Given this list of marker genes TTI2, PAFAH2, RGS20, F11-AS1 (F11 antisense RNA 1), ITSN1, MSANTD2, MED12L, MRPL3, PCLAF, IPCEF1, EFNA5, SRF, STRIP1, EFCAB6-DT, TXN2, CCNC, UNK, YAP1, KIFAP3, ABI2, UBE2V1P14, ZNF575, SNORD27, RPL21P40, VPS28, SCFD1, C11orf98, ALKBH2, CYB5B, CPEB2, RPS26, LINC02716, DAGLB, KANSL3, UTS2, RNU4-9P, RN7SKP95, N4BP2L2, LINC00705, TLN1, FAM133B, SRCAP, B2M, SCAF1, HUS1, UBE2Z, LINC02739, SFSWAP, CCDC107, COX7A2L, ATG101, PPIG (NCBI Gene Id 9360), ELMO1, GIN1, GPSM3, CASP7, KDM1A, DRG2, LRRC14, ARHGEF1, HSPE1-MOB4, XRN1 (NCBI Gene Id 54464), ENSG00000255357, GSPT1, FBXO4, MFSD4A, FBXW5, KIAA0319, ATXN2L, H4C3, SNAP47, HNRNPA1, MRPL30, TTC21B, CYYR1, TMEM242-DT, TUBB, TAFA2 (TAFA chemokine like family member 2), SLAMF1, RAD1, NOB1, ENSG00000252188, FBXO34, SEC62, METTL18, EMG1, C9orf43, RNU6ATAC32P, SYMPK, PVT1, NWD1, NELL2, EIF3H, METTL13, MT-TW, SLC3A2, CTSA, DROSHA, ENSG00000253214, MAP3K7, FOXRED1, BRD4, UBB, TOP3B, SMG8, PDCD6, CTSC, SMIM8, EVI2B, TAS1R1, TBC1D17, INO80C, GUSBP1, PFDN4, ERVK3-1, FUT11, RPS7, GABARAP, RPL10A, MDP1, PRMT5, VAMP1, TPRG1, RPL22, GBA1LP (glucosylceramidase beta 1 like, pseudogene), PRCP, PNPLA8, TMEM108-AS1, WDR70, LINC02794, SNORD15A, MCL1, FBXW2, TIMM44, NR1H3, IMPDH2, NKAPD1 (NKAP domain containing 1), LINC01775, NEU4, CNN3, BTG1-DT, ERRFI1, TXNRD2, TLE6, RTRAFP1, BANP, MIR4503, HCG20, LYSMD1, RPS13P5 (NCBI Gene Id 100271061), ACAD8, DDX5, SMAD6, CDC40, TIA1, TAF13, DYNC2I2, USP22, DNAJB4, RPL24, SNORA57, PACERR, ALOXE3, AMBN, SLC25A5P7, ANG, RCC1, BSCL2, TMPO-AS1, LINC02609, SLC25A25, CLCC1, KDSR, C12orf57, SCAI, SNORD26, TMEM241, PIH1D2, ARIH1, HIGD2AP2, TBL1X, TFG, RRAS, PDCD6-DT, ZNF770, RBBP5, ATXN7L1, EIF4E2, SCG2, PAK1, CYP4F22, SNORA8 (NCBI Gene Id 654320), ULK3, FRS3 (NCBI Gene Id 10817), DBF4B, SPARC, FBXO34-AS1, FADS2, DNAJC9-AS1, ATP6AP1L (NCBI Gene Id 92270), FUS, NUFIP2, EIF3F, PLEKHA3, ERCC1, COA5, NUDT17 (nudix hydrolase 17), THOC5, UBQLN1, SLC25A21, RNY4, TACO1, MRPL34, HDHD2, PRR7, EXOSC3, METTL1, LY6K, ELP3, H2BC8, SYCE2, CCDC97, VPS50, C8orf82, RINT1, IL4I1, TUBA1B-AS1, STEAP1, SREBF2, DDX19A, COA6, NUAK1, TRNAU1AP, KCNIP2-AS1, MRPS23, COL6A5, NLRC5 (NLR family CARD domain containing 5), MSTO2P, CHD1, PDE4A, GSTA4, DHRS13, TMEM138, DMAP1, ALDH1A2, AURKAIP1, RPL10, TMEM183AP4, MIR4512, AFMID, SBDSP1, RBM39, REX1BD, MIR4645, TRAJ35, RUVBL1, JMJD4, GALK2, FBXO11, CYCSP26, LTBP4, PRPF18, RUBCNL, CECR3, TGIF1, ZBTB45, LAMA4, ZNHIT2, PPP1R1C, HSPE1, TM9SF3, MINCR, DUSP6, CNIH2, CREB3, ENSG00000255476, SEZ6, OTOGL, MEPCE, PABPN1, COX16, SEL1L3, RBMS3, PRR7-AS1, SFTA2, PDE8A, PARP2, RBM11, STAT1, ENSG00000181123, SEC13, LINC01089, SNRNP35, IMMT, RN7SKP175, TPH2, SSBP2, MAPK1IP1L, NFX1 (NCBI Gene Id 94733), PEBP1P1, LDLRAD4, TEDC2 (tubulin epsilon and delta complex 2), ENSG00000268129, RPS23, RPL26 (NCBI Gene Id 6154), TRIB1AL, EFCAB6, GNG12-AS1, ASPH, TMEM260, BBS4, RMDN3, UBFD1, SETD5, KIAA0586, WEE2-AS1, FEZ2, NCOA7, ZNF687, SNU13, MEIS1, SLC39A8, ALKBH5, RPS18, RGS12, H4C13, NOSIP, RETSAT, F5, LINC02847, NME1-NME2, EXOSC4, TMEM39A, TTLL3, KLHL22, GLUL, PRRT1, PTP4A2, SAV1, PTCH1, B3GALT9, TNFAIP6, RUNX2, PXMP2, PNPT1, NUDT4, REXO4, ELP5, HIGD2B, C11orf91, DIXDC1, RDH11, IL16 (interleukin 16), PDE7B-AS1, PTCD1, RNASE4, GBA1, NGRN, LRATD2, ARRDC3, TBC1D4, ZNF423, NRDC, SEH1L, PHB2, NAIF1, MT-RNR2, UQCRH, AGAP2-AS1, VOPP1, ADAM28, CSKMT, RMRP, RBM25, MEX3C, U2SURP, ANKRD28, RNU6-899P, FPR3, PSMA1, VPS51, RAD23A, ZNF34, PCDHA13, POLG2, ZNF76, SPCS2, CHAMP1 (NCBI Gene Id 84453), GFM1, XRRA1, PRDM10, LINC01363, THYN1, LINC02909, POLE3, FFAR3, LINC00690, UTP3, RBM28, RNA5SP436, LIMA1, FIBP, NACA, ACBD4, STK19 (serine/threonine kinase 19), TANC2, STT3A, SSBL4P, ZNF837, SAMD4A, PRRG2, CD82, HSPD1P1, PDIA5, TOMM6, SNX1 (sorting nexin 1), NFIC, UBXN1, XBP1 (NCBI Gene Id 7494), RNU7-27P, ZNF212, KIAA1586, VPS52, KIAA1217, CASC11, GEMIN6, NOC3L, TMEM222, FAM53C (family with sequence similarity 53 member C), PPP1R10, POLI, ZNF767P, ATAD3A, RPS4X, CEP120, SCGB2A1, LINC03017, EIF1AD, C22orf46P, LMLN, RNU1-19P, WDR35, EPHA4, PPIF, LINC01495, POLG-DT, RBM4 (RNA binding motif protein 4), SNORD5, RRP15, ACP2, ZFAT (zinc finger and AT-hook domain containing), HCG14, CALM1, RPL27A, BCAR3, P4HB, AP2M1, HHAT, SLC7A11 (solute carrier family 7 member 11), CDK5RAP2, NUP62, NPRL3 (NCBI Gene Id 8131), CASTOR1, CENPU, PPP1R37, LINC02309, ATP6V1D, SNORD25, PTGS2 (NCBI Gene Id 5743), NCAM1, LINC02098, COMMD9, MTF2, RNU6-2 (NCBI Gene Id 103625684), SNTG2, BAZ2A, THAP7-AS1, COPS7A, MFSD6, USP2, HNRNPF, ZNF318, C8G, LINC01569, SETD6, UBC, CTDNEP1, RAB11A, DDB2, UTRN (NCBI Gene Id 7402), CDC25C, SCNM1, COPS2, PLEKHG7, BDNF, NCK1, H1-10, GGACT, RNU6-1, CFDP1, MIR5087 (microRNA 5087), MIRLET7A1HG, NAT10, SELENOH, ZNF513, WBP1L, SUPT20H, RNU6-1055P, PPIB, LRRC41, ZNF131, CHD2, RPL7AP57, SNHG1, XRCC2, SNRNP27, ZNF668, INPPL1, JPX, SRPRA, APOH, ATG16L1, ETV6, HM13-AS1, DYNC1I2, MTIF3, SRSF5, METTL15, TRAJ3, LSG1, FERMT3, NRCAM (neuronal cell adhesion molecule), PRPF4, LINC01322, ZNF428, ZC3H10, MALAT1, ESYT1, LINC01812, VPS41, SPRYD4, H4C6, KDM3B, TOB2, TNRC6C, C2CD3 (NCBI Gene Id 26005), PAFAH1B1, PROSER2-AS1, TAP2, CTNND1, CWC27, DLGAP4, RPL7L1P13, SLC25A51, LINC02695, HTATSF1P2, RPL21P126, NAPA, LINC02846, POM121, DHPS, HTD2, MT-TV (mitochondrially encoded tRNA-Val (GUN)), PPP1R21, CDKAL1, ADPRHL1, QSER1, VPS4B, LAPTM4A, RNF121, HIPK1-AS1, TIMM9, NEURL2, EYS, NOL9, UNC50, DIAPH1, ACTB, VWA5A, MIR759, HMCN1, EXOSC6, POLQ, RNU7-90P, TMEM259, LINC01960, ARL14EP, MAPK8IP3, TTF2, OSTM1, BOLA1, TK1, SIRT6, KCNIP1 (potassium voltage-gated channel interacting protein 1), MTCO3P12, ANKRD40, ZNRD2, SSBP1, VARS2, EPB41L4A-AS1, TMEM258, HCG21, PWWP3A, MAGEF1, EEF1A1P25, PLEKHG2, ZNRD2-DT, DNM1L, FBXW9, SRSF7, BYSL, TUT1, CYTH1, KIF18A, ABCA5, KAT7, ATP5PO, IL34, ISY1-RAB43, CYB561A3 (NCBI Gene Id 378885), RPS24, H2AC21, UBA52, DIP2C, CASP9, LINC01719, MYBPC1, THAP1, MYOM2, TARS2, ABHD16A, USP2-AS1, TRD-AS1, ELMOD3, MED20, OGA, ITFG2, BMPER, SMG7, PPME1, HCG24, RNU12, PSMC4, SMIM27, PCBP1-AS1, ARID1A, LUZP1, HNRNPR, PRKAG1, XKR5, MICU1, LINC01132, MORC3, CD68, TAF3, TENM2, PIGC, SDC4P, ATP1B3, TRIP4, GPATCH2L, IRF2-DT, PPT2-EGFL8, GRAMD4P8, LINC00426, SFT2D3 (SFT2 domain containing 3), GEMIN8, MAP4K3-DT, CDK5RAP1, BMPR1A, ADAT1, TAF1D, CRK, LIMS1-AS1, STC1, SLC9A1, FBXO31, CNPY4, LBR, SNX19, MARVELD3, EIF2AK2 (NCBI Gene Id 5610), IQCG, GPX1, SNAPC5, LOXHD1, CYREN (cell cycle regulator of NHEJ), SH2B1 (SH2B adaptor protein 1), ENSG00000267764, INTS4, PEX2, ZC3H3, RHOH (ras homolog family member H), MED18 (mediator complex subunit 18), TIGD1, AKT1S1, SNORA13, TRMT12, C19orf53, SLC30A4-AS1, ZAR1L, KLHL20, SNORD3A, SNHG12, DLGAP1-AS2, POLR2M, SOX6, COL20A1, MAZ, NEB, ARHGAP26, TRAPPC3L, LINC01275, SMARCC2, HSPD1, NDUFAF4P1, BTG1, SYT16, C2orf42, CUL5, LINC02732, AP5S1, THBS3-AS1, TRIO, IFTAP, TRMO, MRPL38, BBOX1-AS1, RASAL2, ZKSCAN4, ENSG00000248161, EFCAB5, CCDC80, ANXA11, SLC35C2, ENSG00000200538, JPT1, NEK3, HABP2 (NCBI Gene Id 3026), DIAPH1-AS1, TPM1, PAF1, LRP3, CCAR2, MIR4799, TIMM10, GS1-24F4.2, IRF2 (NCBI Gene Id 3660), TINF2, RNU4-91P, MRPS18CP6, FDX1, DDX19A-DT, ATG16L2, METTL26, IRF9, WRAP53, WDR35-DT, PIK3CG, CEP95, CHD7, GORAB-AS1, CCNY, PSEN1, TMEM232, ATF5, RCN3, LINC01571, TMEM242, SLC33A1, SEMA3A, RBMS3-AS3, MDM4, SMARCD2, RBMS3-AS2, ZNF846, DNAI3, ANKRD13C-DT, FAM43A, FIRRM, JAKMIP2-AS1, NDUFV2, TRAPPC12, UBA1, CCDC102B, KRT127P, AKAP13, COL21A1, NME1, FOCAD, ZNF43, DNAJC16, NEMF, C11orf54, TMC1, MRPS15, CRABP1, MIR924HG, PTPA, RPS3, KCTD14, PPP6R1, BRIX1, NOL7, KNL1, CLIP1, ATP7A, PAXBP1, MITD1, ZNF778, ATF6, ZNF532, HCLS1, UTP25, MRPL19, EIF2S1, CLPB, TFAP2A, CLASP1, POLG, PPT2, ZEB2, RNU6ATAC, DNAJB14, ARHGAP21, MPP4, PLPP6, BPHL, ZCCHC4, BANF1, SLCO4A1-AS2, ROBO3, TBPL1, CCDC9, SHTN1, ITFG2-AS1, TUFM, ZW10, AAAS, HNRNPA2B1, GTF3C3, LINC02218 (NCBI Gene Id 102723526), TSG101, AOX1, GLI1, APRT, CARS1, AP1M1, MED6, CACYBP, MIATNB, ISY1, CDC42EP5, PSMD9, PRKRIP1, CNOT11, MIRLET7A1, EEF1AKMT3, DXO, WASF1, SMG7-AS1, THUMPD3-AS1, GSAP, GADD45B (NCBI Gene Id 4616), NR1H2, LRCH1, HIPK1, SMURF2P1, LINC02104, BDH2, GADL1 (NCBI Gene Id 339896), SMAD3, PREP, CLTC, TLN2, FZR1, SCAT8, AMOTL1, FAM98B, STK17A, MIRLET7F1, CPSF4, SAMD1, MIPEP, SRBD1, ZBTB11, CYP4V2, EPCIP-AS1, UNC80, RGL2, SNORA16A, SDHAF2, CRBN, CD101-AS1, RLIM, RAB2A, KLHDC2, MCRIP2, MCOLN1, ADRA1D, MIR5695, PLD1, NDUFC1, KIFC3, YTHDF2, ROCK1, HIKESHI, DPP9, CDC42SE2, MYEOV, NOLC1 (nucleolar and coiled-body phosphoprotein 1), TMEM170A, MAP2, POLE, THAP7, XXYLT1, LINC02304, KDM4B, ZNF549, LAPTM4A-DT, ZFYVE16, RPP14, RNU7-88P, POLDIP3, HMOX2, FUT10, KRTAP5-14P, CYC1, CRYZL1, ADPRS, MAD1L1, IGF1, RBM14-RBM4, ZNF350, SNHG17, ATXN7L3B, ALKBH3, MED29, ARMC1, F11, ATF6-DT, RHOF, TOMM40, ASXL1 (ASXL transcriptional regulator 1), NCKAP5, FAM200B, PPIA, RNU6-1255P, EPC1, ANKRD24, ZCWPW1, USP15, BRF2, CDK11B, VIT, MIR6853, MT-CO1, COA1, RNF168, LINC01907, PSMD4P1, SCNN1G, MSANTD2-AS1, DGAT1, NT5C, ANKRD13C, LINC01686, LINC01681, MRPS18B, KMT2D, KDELR2, FKBP1A, DNAJC12, MYH9, GRPEL2, GPR137, EPB41L5, LINC02384, RBL1, FCGRT, SYNGR2, H4C8, CPSF7, CDK11A, PPP6R3, RPS27, NDUFS7, MIR5188, LINC02362, XNDC1N, SNHG5, GTF2H4, BMF, DDX41, GRP, DDIAS, SCTR, KMT2A, LRP8, ZNF778-DT, PTPRG, ADD3, PSMF1, LINC02562, SPATA24, EEF1G, WDR74, PRSS23-AS1, IGFL4, TMEM144, REXO1, TRPM1, TCTN3, GRAMD2A, DENND5A, MDN1, ASNS, MTG2, PPIP5K2, EVA1A, MAP1LC3B, SF3A3, POMP, CCDC59, NFKB2, CRTAM, SELENOOLP, RBM14, FN1, NAA35, RNVU1-4, TAF6, SCRIB, EARS2, CAND1, RBM5-AS1, NMRAL1, NECAB3, BRCA2, here is a description of the gene set: Genes containing one or more binding sites for (EWSR1) in their promoter regions (TSS -1000,+100 bp) as identified by GTRD version 20.06 ChIP-seq harmonization. from publication Yevshin I, Sharipov R, Kolmykov S, Kondrakhin Y, Kolpakov F (PMID 30445619) species: Homo sapiens Human Gene Set: EWSR1_TARGET_GENES